Given this list of marker genes TBX5, KAT2B, NPR1, CES1, NPPA, MME, NKX2-5, WWTR1, GATA4, NPPC, NPR2, CORIN, HIPK1, HIPK2, here is a description of the gene set: studied in species Homo sapiens Human Gene Set: REACTOME_PHYSIOLOGICAL_FACTORS Physiological factors